The following is a description of a gene set: studied in species Homo sapiens Genes down-regulated in B lymphocytes: control versus anti IgM. We have previously shown that rheumatoid factors (RF) produced by Fas-deficient autoimmune-prone mice typically bind autologous IgG2a with remarkably low affinity. Nevertheless, B cells representative of this RF population proliferate vigorously in response IgG2a/chromatin immune complexes through a mechanism dependent on the sequential engagement of the BCR and Toll-like receptor 9 (TLR9). To more precisely address the role of both receptors in this response, we analyzed the signaling pathways activated in AM14 B cells stimulated with these complexes. We found that the BCR not only serves to direct the chromatin complex to an internal compartment where it can engage TLR9 but also transmits a suboptimal signal that in combination with the signals emanating from TLR9 leads to NF-kappa-B activation and proliferation. Importantly, engagement of both receptors leads to the upregulation of a group of gene products, not induced by the BCR or TLR9 alone, that include IL-2. These data indicate that autoreactive B cells, stimulated by a combination of BCR and TLR9 ligands, acquire functional properties that may contribute to the activation of additional cells involved in the autoimmune disease process. from publication Busconi L, Bauer JW, Tumang JR, Laws A, Perkins-Mesires K, Tabor AS, Lau C, Corley RB, Rothstein TL, Lund FE, Behrens TW, Marshak-Rothstein A (PMID 18025183) Human Gene Set: GSE6674_UNSTIM_VS_ANTI_IGM_STIM_BCELL_DN, and this is the list of marker genes: ADAMTS9, SCUBE2, TNFRSF17, SPMAP2L, TNFRSF9, NR4A2, LDLRAD1 (low density lipoprotein receptor class A domain containing 1), CCDC60, GATA2, TBX21, BDKRB1, OTP, CD5, CLEC4D, VIPR2, LMOD1, CYP7A1 (cytochrome P450 family 7 subfamily A member 1), OMP, BMP7, STYXL2, ASB14, BTN1A1, PSORS1C2, SCGB1A1, TRPV5, CSN2, DLL4, DCN, ROPN1, FAM83A, CKM, MSLNL, TXN, TMEM184A, DDI1, CIMAP1A, DOC2B, NAALADL1, CABP7, NCALD, GPIHBP1, PBLD, GPR37L1, MARCHF11, ERN2, MELTF, PIH1D2, LELP1, RGS6, COL17A1, IFITM1, TECTA, MIR365A, PTPRZ1, MIR34C, SH2D6, LHX2, RPL7A, GP1BA, DRGX, ARHGAP22, NEUROD1, RRH, SGIP1, ARMCX4, SLC22A14, ZFP92, GABRG1, TACR3, MIR221, TMEM179, PANX2, AQP5, PTGFR, F2RL3, CHRM4, SAPCD2, EPPK1, ANKRD42, PDCL2, MRGPRG, MAPK15, MPTX1, GRAMD2A, MED12L, BGLAP, TEX55, WFDC1, FA2H, CHST10, FXYD7, MTHFR, NFASC (neurofascin), GDF6, CHRNB4, SLC17A2, BARD1, FOXR1, IRF7, SHISA4, KRTAP5-3, ENTREP3, PTHLH, GJA4, USP18, CHRNE, RPS3 (ribosomal protein S3), KRT73, SCARA5, IL1B, SYNDIG1L, ASTL, CD14, SCML4, ANKEF1, LRRC75B, RFPL4B (NCBI Gene Id 442247), KRT75, TEAD1, SUSD4, STEAP4 (NCBI Gene Id 79689), SYNGR3, MYL10, ATP2B3, ABHD12B, GABRR2, SYT15, KRTAP17-1, CACNG5, KDF1, SPC24, KLRG2, ZBTB32, BAHCC1, KCNA1, HRC